The following is a description of a gene set: A structural abnormality of the fetal circulation system. Terms in this subhierarchy are restricted to findings that can only be observed in the prenatal period. Other HPO terms can also be used to describe fetal phenotypes. studied in species Homo sapiens Human Gene Set: HP_ABNORMAL_FETAL_CARDIOVASCULAR_MORPHOLOGY Abnormal fetal cardiovascular morphology, and this is the list of marker genes: TLK2, WT1, DPYSL5, PIGY, GATA6, GNB2, PAK2, PIGO, CRB2, PGAP2, MDFIC, NRAS, TWIST2, WNT3, SCARF2, PACS1, SPECC1L, STAG1, CLXN, PIGL, QRICH1, WASHC5, TAPT1, MYH7, PGAP3, FOXF1, LARS2, MAX, POR, CAPRIN1, ZNF699, RYR3, MKS1, HPS6, FAT4, FANCF, CACNA1C, RHD, HNRNPK, HOXD13, PIGW, CCDC22, HSPG2, PIGV, FANCB, RAC1 (Rac family small GTPase 1), MCTP2, TRAF7, SLC30A9, VPS35L, THSD1, DDX6, DPF2